Given this list of marker genes EXOSC9, MPP2, DNAAF6, NCDN, TP53BP1, MARCHF1, KATNAL2, MRAP2, DGKI, TMEM178A, PLD5, BTG2, ATP13A4, CP, STX5, SEMA4B, HOXD4, KRIT1, RWDD1, SELPLG (NCBI Gene Id 6404), FRMD4A, TSC22D1, SPAG9, CRH, NLGN2, NDST1, P2RX4, C2CD2L, PPM1E, ZP1, KLHL41, CAMK1, MEOX2, AKAP3, TNFRSF8, B9D2, LIX1, GNA13, MAX, TSHZ3, OSR2, TNKS, NUP62CL, SIDT1, CFAP298, CAMK2D, TYRO3, FEZF2, SHANK2-AS3, RNF207, ELMO1, MGP, CITED1, ZNF768, OMA1, PTK7, ROGDI, EPX, CYRIA, SLAIN1, NR1D1, SPARC, ASCC1, HPCAL4, ZEB2, ARAP1, ZFYVE1, SLC34A3, MORN4, TTF1, CAMK2A, SLC44A1, FSIP1, POU4F2, CDK2AP2, FOXO4, FAM53B, GRHL2, QRFP, PPP2R2B, NDUFC1, PRKACA, GIPR, RHOBTB1, RCAN1, DNM2, ABLIM3, MOK, here is a description of the gene set: Comprehensive identification of all functional elements encoded in the human genome is a fundamental need in biomedical research. Here, we present a comparative analysis of the human, mouse, rat and dog genomes to create a systematic catalogue of common regulatory motifs in promoters and 3' untranslated regions (3' UTRs). The promoter analysis yields 174 candidate motifs, including most previously known transcription-factor binding sites and 105 new motifs. The 3'-UTR analysis yields 106 motifs likely to be involved in post-transcriptional regulation. Nearly one-half are associated with microRNAs (miRNAs), leading to the discovery of many new miRNA genes and their likely target genes. Our results suggest that previous estimates of the number of human miRNA genes were low, and that miRNAs regulate at least 20% of human genes. The overall results provide a systematic view of gene regulation in the human, which will be refined as additional mammalian genomes become available. Genes having at least one occurrence of the highly conserved motif M117 TGTYNNNNNRGCARM in the regions spanning 4 kb centered on their transcription starting sites. The motif does not match any known transcription factor binding site. from publication Xie X, Lu J, Kulbokas EJ, Golub TR, Mootha V, Lindblad-Toh K, Lander ES, Kellis M (PMID 15735639) studied in species Homo sapiens Human Gene Set: TGTYNNNNNRGCARM_UNKNOWN